Given this list of marker genes IGKV1-5, MAN1B1, VHL, CLTC, IGLV3-1, ITGB1, SEH1L, RPS13, MED13L, H3C13, VPS4A, DAXX, IGHV3-13, CDK7, XRCC5, ISCU, DDX5, FAU, IGHV4-34, IGKV1-17, RPS12, LIG4, SLC25A6, RPL37, RPL30, AKT3, NELFCD, MASP1, ITCH, ST6GAL1 (ST6 beta-galactoside alpha-2,6-sialyltransferase 1), AP2M1, MAP3K7, RPL36, TBL1X, AGRN, B2M, CSNK1A1 (casein kinase 1 alpha 1), SMN2, TUBA4B, GTF2H5, NELFA, H2AC8, FXYD6, UBE2L6, MED17, VPS41, NMT2, GEMIN7, MED18 (mediator complex subunit 18), BRD4, ST6GALNAC3, ELOA2, RPL28, VCP, IPO5, XRCC4, LY96, GPC5, IGHV3-23, NUP133, GTF2H2, NCBP1, RPS5, PSMA1, TLR4, CBX1, HLA-B, H2BC3, RPL23, IGHV1-46, NCBP2, ELOB, NUP35, SPCS1, RAB5B, CD8B, CD79B, CRBN, CDK9, HCK, RPL39, MGAT2, TUBB8B, LARP1, NUP50, PSMD6, DYNC1LI1 (dynein cytoplasmic 1 light intermediate chain 1), MED8, TLR3, IGHV3-53, NUP42, RPS16, RPL38, NPM1, NUP153, LCK, FNTA, IGKV5-2, IGHM, SMAD3, UBE2V1, RPS21, TAF10, GSK3B, PARP4, RAC1 (NCBI Gene Id 5879), NUP62, CCNC, SEC24C, YWHAB, NUP160, RAB5A, PKLR, CUL3, RAB5C, RPL10L, XPO1, IGLV3-19, IFNB1, TAF5, RPL18 (NCBI Gene Id 6141), H3C3, GRB2, TRIM25, PTPN6, MED24, RAN, H4C14, SPCS2, IGKV1-12, IGKV2D-30, PPIH, IGKV3-11, ZBP1, MED19 (NCBI Gene Id 219541), IFNA17, IGLV2-14, H2AC11, TLR8, ROCK1, HDAC1, IKBKG, H2BC21, TUBB2B (NCBI Gene Id 347733), ERCC2, PRKCSH, SSRP1 (structure specific recognition protein 1), TUBA3C, RPS23, RPLP2, CDK8, NELFE, IFNAR1, IGHV2-5, GEMIN5, PDCD1, PSMC3, H2AC17, KPNA2, PSMD1 (NCBI Gene Id 5707), UVRAG, IGLV6-57, NPIPB3, CX3CR1, TAF13, SEC24A, TAF6, CHMP2B, IL1R1, TUBA1B, MED22, H4C1, IGKV1D-33, ZCRB1, MED31, RPS4X, IFNA6, RPL7A, ITGA4, SEC24B, H3C1, H4C2, AP1S2, TUBA3E, NEDD4L, MGAT1, H3C7, PARP9, ATP6V1H, CHMP6, DYNC1LI2 (NCBI Gene Id 1783), MOGS, RPL39L, CNBP, PSMA6, NMI, EP300, RB1, RPL10, GSK3A, IGHV4-39, TAB2, NUP93, VPS37C, HSP90AB1, BTK, POM121, AP1G1, TUSC3, RCC1, IFNA10, PSMC1, SNRPB, PSMD3, RPS15, RANBP1, IGKV2-30, ZDHHC20, RPL9 (ribosomal protein L9), GEMIN6, NUP85, YWHAQ, RPL26, GATAD2A, RELA, ARF1, IGLV2-11, RPS9, ELL, FXYD2, PPP1CC (NCBI Gene Id 5501), TBK1, ST3GAL2, GTF2F1, SUPT4H1, MAP1LC3B, H4C5, PSMB3, H2AC25, CD247, VPS18, CHMP2A, FXYD7, ANO1, GEMIN4 (NCBI Gene Id 50628), H3C8, SPCS3, VPS4B, TAF11, NLRP3, PSMC4, POLR2G, H4C11, IFNA7, HLA-C, ZDHHC2, RPL23A, IGHV4-59, TSG101, IGKV2-28, SIKE1, NDC1, DYNLL2 (NCBI Gene Id 140735), TAF1, TAF4B, CYSLTR1, PRMT1, SDC3, RPS26, HDAC2, TAF12, KPNB1, NCOR2, GTF2H3, GTF2E1, EEF1A1, PAK2, VPS37D, ANO3, AP2A2, IGLV3-27, RPL41, H2BC1, CHD4, RPL3, RNMT, H2BC10, HLA-E, KPNA1, EED, TYK2, UBE2I, GPC4, TUBB6, RBBP4, G3BP2, CTDP1, POLR2C, NMT1, RPL29, XRCC6, IGKV2D-40, HLA-G, LIG1, DYNC1H1, ATP1A2, GPC3, H2AC12, ANO8, PSMA5, TUBA1A, CCNT1, RUNX1, H4C15, KPNA4, RPL18A, ELOC, POLR2A, ST6GALNAC4, GTF2H4, IGHV3-7, RPLP0, MED29, H2AC20, ZDHHC5, SOS1, TUBA1C (tubulin alpha 1c), IGLV7-43, MGAT4A, IGLC2, MED28, RPL15, IFNGR2, TAF1L, ANO5, VPS37B (NCBI Gene Id 79720), COMT, MED14, POLR2E, RPL19, CPSF4, HLA-F, POLR2B, NFKB1, TPR, GPC1, NOD2, FXYD4, PHF21A, IGLV1-51, GTF2H1, ATP1B3, IFIH1, IGKV1-39, DAD1, RNGTT, ZDHHC8, STT3A, MED30, HMGA1, ARID4B, CASP1, GEMIN2, IRAK2, RPL12, MBD3, PSMD12, DDOST, MGAT4B, H3C2, RIPK2, H4C12, IL17F, VPS33B, RPL35, CD79A, GTF2A2, YWHAE, ATP1B1, H2BC14 (NCBI Gene Id 8342), UBE2N, FKBP4, CD28, TUFM, PARP14, TAF7, RPL34, RPL5, VPS28, POLR2K, IGKV3D-20, PSMC2, IKBKE, RPL11, IGKV3-15, ATG14, STING1, SLC25A4, IGF1R, HLA-A, NUP43, MVB12B, MED21, VPS33A, PSMD8, H2BC11, ERCC3, SEM1, APOBEC3G, ACE2, TAF9, IGLV2-23, H2BC15, NCK1, SUPT16H, RPL6, UBB, CCR5, SUMO1, VPS25, ATP1B2, CHMP4C, CHMP5, H2AC7, CRB3, VPS39 (VPS39 subunit of HOPS complex), ELOA, ATP1A3, NUP155, SDC4, POLR2D, ST3GAL3, RPS27, UBC, RPL31, H2BC17, RIGI, TUBB4A, TRAF6, ANO4, PSMD2, H3C4, NCL, ANO6, SKP1, RPS18, DYNLL1, STAT2, POM121C, RANBP2, IGHV2-70, CDK19, IMPDH1, OST4, SUZ12, SNRPD2, MED25, H4C16, MAVS, NUP107, H2AC6, H2BC18, H2BC8, H2AC15, MED15, IFNGR1, MTA2, RPL8, SFTPD, PATJ, TUBB3, CCNT2, OAS2, H2AC21, FKBP1A, VPS36, PSMD14, KDM1A, TOMM70, FXYD1, MAN2A1 (mannosidase alpha class 2A member 1), GTF2F2, HSPG2, RPS6, YWHAH, NUP88, SNRPD3, PPP1CB, RPL27, NUP54 (NCBI Gene Id 53371), IGKV3-20, IRF7, EIF2AK2, NUP205, RPL10A (NCBI Gene Id 4736), PPIB, SNRPE, PSMA3, JAK3, PSMC6, TUBB4B, CHMP4B (charged multivesicular body protein 4B), RANGAP1, CSNK2A2 (casein kinase 2 alpha 2), VTA1, IGLV1-40, IRAK1, CXCR4, PML, NRP1, MED11, H2BC13, ANO7, SDC1, TRIM4 (NCBI Gene Id 89122), POLR2H, SRPK2, HSP90AA1, NUP37, CHUK, RPL4, PARP10, RPN1, H2BC26, RPN2, TAF3, TAB1, SEC24D (NCBI Gene Id 9871), PIK3R4, REST (RE1 silencing transcription factor), H2AC16, PYCARD, TBP, NUP58, CHMP3, ANO10 (anoctamin 10), GPS2, RBBP7, AP2A1, SH3KBP1, SEC13, TUBB, UBAP1, AKT2, ZDHHC11, RPL3L, IGKV1-16, PPIG, MNAT1, RPS10, RPS7, TAF7L, CTSL, NUP188, TUBB8, IGHV3-48, GJA1, NELFB, TLR1, CLTA, ARIH1, IGKV2D-28, IL17A, IGLV3-25, RCOR1, RPS3A (NCBI Gene Id 6189), H2AC4, CHMP7, VAV1, JAK1, RPS2 (ribosomal protein S2), MED1, GANAB, IFNA1, PARP6, PSMB1, TAF2, TJP1 (NCBI Gene Id 7082, tight junction protein 1), RBX1, HAVCR1, RPS4Y1, EZH2, GPC6, SNRPF, RPS17, SAP18, PABPN1, AP1S3, SUPT5H, IGLV1-44, DYNC1I1, H2BC7, HSPA8, H2AC1, H3C6, TUBAL3, IGLC3, PSMB2, RIPK1, H2BC4 (NCBI Gene Id 8347), TKFC, PPIA, FURIN, PCBP2, H3C12, TLR7, MAGT1, RPL24, AP1M2, EGFR, ATP1A4, MTA1, PARP16, CALR, MED16, IFNA2, CSNK2A1 (casein kinase 2 alpha 1), BTRC, PDPK1, NFKBIA, RPS19, IFNA16, RPS29, ANO9, PSMD7, MED13, PSMB5, IL6R, FNTB, IFNA8, RPL17, GEMIN8, TCEA1, S1PR1, RPL13, IGHV1-2, RPS4Y2, RIPK3, IGHV3-30, IL17RC, H2AC14, IFNA4, SMN1, SEC11A, PSMA7, RPS14, H4C9, G3BP1, EDEM2, NR3C1, IRF3, IGHV3-33, RPS27A, CSNK2B, CAV1, RPL37A, GATAD2B, RPS27L, H4C13, TLR2, IGKV1D-12, RPL21, PLCG2, IFNA5, MED27, SAP30L, CD209, GALNT1, HNRNPK, TLR6, DOCK2, SP1, AP2B1, CHD3, POLR2F, IFNA13, RPL13A, BANF1, TUBA3D, SDC2, AP1B1, RPS11, RPS3, TBL1XR1, CHMP4A, TAF15, MED12, MED23, DYNC1I2, TAF9B, VPS37A, ZDHHC9, TUBB1, VPS45, ADRM1, YWHAZ, H2BC9, TAB3, HERC5 (HECT and RLD domain containing E3 ubiquitin protein ligase 5), RPL32, VPS11, CCNK, PPP1CA, RPL36A, STT3B, FXYD3, GPC2, CREBBP, PTGES3, HMG20B, ELK1, TAF4, MED26, BCAP31, KEAP1, GRSF1, BST2, NUP210, H3C10, FYN, ANO2, RPS25, TRIM28, SFN, TLR9, TUBA4A, SYK, RAE1, PACS1, BCL2L1, MED20, H2AC18, IGKV1-33, NLRP12, IGKV1D-16, RPL35A, H2BC12, VEGFA, PSIP1, FUT8, CD14, HNRNPA1, PALS1, IGKV1D-39, NUP98 (nucleoporin 98 and 96 precursor), RPL22L1, RPLP1, RNF135, CCNH, SIGMAR1, SNRPD1, MAP1B, H2BC5, KPNA7, IFNA21, GOLGA7, RPS28, H4C8, ATP1A1, PSMD13, SEC23A, IKBKB, KPNA5, PIK3C3, CLEC4M, STAT1, PTPN11, PSMB4, MTA3, FEN1, PSMA4, NCOR1, MED9, SUDS3, RPL36AL, CREB1, SMAD4, SRPK1, BECN1 (NCBI Gene Id 8678), RPSA (ribosomal protein SA), ISG15, CUL5, H4C3, IGHV1-69, AP1M1, NUP214, JAK2 (Janus kinase 2), ST3GAL1, ZDHHC3, RPS20, CD4, BRMS1 (NCBI Gene Id 25855), IGLV2-8, PSMA2, RCAN3, CEBPD, DNAJC3, H3C15, PSMD11, AKT1, TMPRSS2, IGLV1-47, KPNA3 (NCBI Gene Id 3839), IMPDH2, PARP8, MGAT4C, ST3GAL4, RPL26L1, SNRPG, IFNA14, SAR1B, POLR2I, MBL2, TUBA8, GTF2B, CANX, RPS8, MVB12A, IGKV4-1, PSMB7, GTF2A1, VPS16, BLNK, SERPINE1 (NCBI Gene Id 5054), MED6, AP2S1, NFE2L2, MED7, TGFB1, RPL14, PDCD6IP, TRAF3, IGHD, POLR2J, RPL22 (ribosomal protein L22), UBA52, RPL7, HDAC3, OSTC, DDX20, H4C6, ELMO1, TMEM258, PSMC5, HSPA1A, H4C4, YWHAG, SAP30, SLC25A5 (solute carrier family 25 member 5), H2BC6, CHMP1A, IFNAR2, MED10, H2AC19, PSMB6, ROCK2, H3C14, AP1S1, NOD1, MGAT5, H3C11, POLR2L, RPS24, H2AC13, TUBB2A, MED4, IGHV3-11, IL17RA, MASP2, SEC11C, SNF8, GTF2E2, RPS15A, AAAS, ST6GALNAC2, RPL27A, IGLV3-21 (NCBI Gene Id 28796), ARID4A, PARP1, here is a description of the gene set: Viral Infection Pathways Human Gene Set: REACTOME_VIRAL_INFECTION_PATHWAYS studied in species Homo sapiens